The following is a description of a gene set: Genes positively differentially expressed in cell type: CD8+ T cell upon treatment with cytokine: IL-27 in mouse lymph nodes in vivo. species: Mus musculus Mouse Gene Set: CUI_T_CELL_CD8_IL27_RESPONSE_UP Cytokines mediate cell-cell communication in the immune system and represent important therapeutic targets. A myriad of studies have highlighted their central role in immune function, yet we lack a global view of the cellular responses of each immune cell type to each cytokine. To address this gap, the authors created the Immune Dictionary, a compendium of single-cell transcriptomic profiles of more than 17 immune cell types in response to each of 86 cytokines (>1,400 cytokine-cell type combinations) in mouse lymph nodes in vivo. A cytokine-centric view of the dictionary revealed that most cytokines induce highly cell-type-specific responses. For example, the inflammatory cytokine interleukin-1β induces distinct gene programmes in almost every cell type. A cell-type-centric view of the dictionary identified more than 66 cytokine-driven cellular polarization states across immune cell types, including previously uncharacterized states such as an interleukin-18-induced polyfunctional natural killer cell state. from publication Cui A, Huang T, Li S, Ma A, Pérez JL, Sander C, Keskin DB, Wu CJ, Fraenkel E, Hacohen N (PMID 38057668), and this is the list of marker genes: Samhd1 (NCBI Gene Id 56045), Ifi27l2a, Gimap4, Apobec3, Zbp1 (NCBI Gene Id 80562), Psmb9, H2-T23, Ppa1, Plaat3, Plac8, Ifi47, Psma2, Isg15, Bst2, Ly6a (lymphocyte antigen 6 family member A), Psmb8, Psme1, Stat1, Irgm1, Psme2, Psmb10, Ms4a4b, Igtp, Irf7, Gbp4, Rnf213, Gbp2, Tapbp (NCBI Gene Id 28066)